The following is a description of a gene set: studied in species Homo sapiens Trophoblast cell migration that is accomplished by extension and retraction of a pseudopodium. Trophoblast cells line the outside of the blastocyst. Human Gene Set: GOBP_TROPHOBLAST_CELL_MIGRATION, and this is the list of marker genes: ARHGDIB, SMAD3, MSTN, ACVR1B, SMAD2, YTHDF3, APELA, ACVR2B, CALR, TIMP1, ACVR1C, MIR16-1, NODAL, GJA1, SYDE1, FBN2, ITGB3, VEGFA, AGO2, C1QBP (complement C1q binding protein), MMP2, ITGB4, TGFBR1, SMURF2, MIR15B